Given this list of marker genes Ephx1, Rorc, Vdac2, Gpr183, Cav1, Vdac1, Smo, Insig1, Rora, Tmem199, Insig2, Gpr141, Gas1, Tmem97, here is a description of the gene set: Mouse Gene Set: GOMF_OXYSTEROL_BINDING species: Mus musculus Binding to oxysterol, an oxidized form of cholesterol.